Given this list of marker genes MIR195, RUNX1, PPARG, MIR34A, MIR34B, MIR15B, PPP3CA, MIR214, MIR34C, MIR17, MIR199A1, MIR16-1, ROCK1, MIR199B, ROCK2, AGER, here is a description of the gene set: Human Gene Set: GOBP_REGULATION_OF_CONNECTIVE_TISSUE_REPLACEMENT species: Homo sapiens Any process that modulates the frequency, rate or extent of connective tissue replacement.